The following is a description of a gene set: Reactome Pathway: RUNX1 regulates transcription of genes involved in differentiation of myeloid cells The RUNX1:CBFB complex regulates expression of genes involved in differentiation of myeloid progenitors which can commit to hematopoietic lineages that lead to generation of platelets, erythrocytes, leukocytes or monocytes.<br>The RUNX1:CBFB complex recruits histone acetyltransferase CREBBP (CBP) to the promoter of the CSF2 gene, encoding Granulocyte-macrophage colony stimulating factor (GM-CSF), thus inducing GM-CSF expression. GM-CSF induces growth, differentiation and survival of macrophages, granulocytes, erythrocytes and megakaryocytes from myeloid progenitors.<br>The RUNX1:CBFB complex directly stimulates transcription of the LGALS3 gene, encoding galectin-3. Galectin-3 is expressed in myeloid progenitors and its levels increase during the maturation process (Le Marer 2000).<br>The PRKCB gene, encoding protein kinase C-beta, which regulates apoptosis of myeloid cells, is directly transactivated by the RUNX1:CBFB complex. species: Homo sapiens part of: Transcriptional regulation by RUNX1, and this is the list of marker genes: LGALS3, CBFB, RUNX2, CSF2, RUNX1, PRKCB (NCBI Gene Id 5579), CREBBP